Given this list of marker genes EIF4A1, PKP1, SYMPK (NCBI Gene Id 9417), RBFOX1, HSF1 (NCBI Gene Id 642255), SUMO1, DHX9, TIA1, here is a description of the gene set: A dense aggregation in the nucleus composed of proteins and RNAs that appear when the cell is under stress. Human Gene Set: GOCC_NUCLEAR_STRESS_GRANULE studied in species Homo sapiens